The following is a description of a gene set: from publication Wang J, Iwasaki H, Krivtsov A, Febbo PG, Thorner AR, Ernst P, Anastasiadou E, Kutok JL, Kogan SC, Zinkel SS, Fisher JK, Hess JL, Golub TR, Armstrong SA, Akashi K, Korsmeyer SJ (PMID 15635450) Chromosomal translocations that fuse the mixed lineage leukemia (MLL) gene with multiple partners typify acute leukemias of infancy as well as therapy-related leukemias. We utilized a conditional knockin strategy to bypass the embryonic lethality caused by MLL-CBP expression and to assess the immediate effects of induced MLL-CBP expression on hematopoiesis. Within days of activating MLL-CBP, the fusion protein selectively expanded granulocyte/macrophage progenitors (GMP) and enhanced their self-renewal/proliferation. MLL-CBP altered the gene expression program of GMP, upregulating a subset of genes including Hox a9. Inhibition of Hox a9 expression by RNA interference demonstrated that MLL-CBP required Hox a9 for its enhanced cell expansion. Following exposure to sublethal gamma-irradiation or N-ethyl-N-nitrosourea (ENU), MLL-CBP mice developed myelomonocytic hyperplasia and progressed to fatal myeloproliferative disorders. These represented the spectrum of therapy-induced acute myelomonocytic leukemia/chronic myelomonocytic leukemia/myelodysplastic/myeloproliferative disorder similar to that seen in humans possessing the t(11;16). This model of MLL-CBP therapy-related myeloproliferative disease demonstrates the selectivity of this MLL fusion for GMP cells and its ability to initiate leukemogenesis in conjunction with cooperating mutations. Top genes up-regulated in granulocyte/macrophage progenitors (GMP) upon expression of MLL-CBP fusion. species: Mus musculus Human Gene Set: WANG_TARGETS_OF_MLL_CBP_FUSION_UP, and this is the list of marker genes: PIAS4, MT1F, CPD, RAPGEF3, STK10, TRUB2, OOSP1, CD14, NCAM1, ADAM15, HOXA9, LAPTM5, ADCY3, YWHAZ, STAC, RGS10, PGLYRP1, SLC38A3, CEP350, MRPL11, DNAH8, TMCO6, CELA1, F10, GTPBP2, LRG1 (NCBI Gene Id 116844), SIAH1, KIF1B, EZR, NR2C2, EVI2A, OGFRL1, ITSN2, P2RY14, WFDC21P, RPL23A, IL12A, FERMT3, LAPTM4B, VCAM1, FAM174B, CENPV, GLG1, GPC1, ATP6V1E1